Given this list of marker genes Pqbp1, Nr2e1, Caprin2, Ptn, Opa1, Rapgef2, Robo1, Dbn1 (NCBI Gene Id 56320), Hecw1, Lzts1, Rap2a, Ss18l1, Camk2b, Actr2, Bmp7, Kndc1, Wls, Sipa1l1, Sarm1, Reln, Camsap2, Prex1, Chrnb2 (NCBI Gene Id 11444), Cdc20, Akap5, Trpc6, Grip1, Cdkl5, Epha4, Cyfip1, Ntrk2, Afdn, Carm1, Dhx36, Hdac6, Arf6, Nsmf, Bmp5, Kalrn, Crkl, Crk, Cul7, Ptprz1, Elavl4, Slc30a1, Stk11, Mir132, Cyth2, Ptprf, Crtc1, Actr3, Dnm1l, Rab21, Dpysl5, Zfp296, Rapgef4, Mfn2, Cask, Numbl, Trpc5, Sez6, Fzd4, Baiap2, Mir212, D130043K22Rik, Stau2, Caprin1, Sema4d, Sh3glb1, Ankrd27, Dab2ip, Grin1, Gsk3a, Khdc3, Zdhhc15 (zinc finger, DHHC domain containing 15), Tbc1d24, Rab17, Tnik, Met, Mark1, Adgrb3, Pafah1b1, Vldlr, Cdkl3, Gorasp1, Gsk3b, Dgkg, Xlr3b, Id1, Eef2k, Obsl1, Ppp3ca, Hecw2, Alk, Bhlhb9, Rhoa, Chrna3, Nfatc4, Ywhah, Bcl11a, Neurog3, Dlg4, Ilk, Pak3, Clip1, Tlx2, Ezh2, Sgk1, Ache, Nedd4, Cux2 (NCBI Gene Id 73417), Mgarp, Fat3, Numb, Pacsin1, Parp6 (NCBI Gene Id 77523), Anapc2, Cobl, Nedd4l, Rtn4ip1, Dbnl, Cux1, Skor2, Il1rapl1, Myo5b, Mfn1, Tiam1, Pias2, Abl1, Tmem106b, Fbxo31, Csmd3, Marcks, Mfsd2a, Itpka, Lrp8, Iqgap1, Wnt5a, Ptprd, Fbxw8, Sdc2, Camk1d, Ephb2, Crp, Cit, here is a description of the gene set: species: Mus musculus Any process that modulates the frequency, rate or extent of dendrite development. Mouse Gene Set: GOBP_REGULATION_OF_DENDRITE_DEVELOPMENT